Given this list of marker genes IFT140, PKD1, LRP5, ALG5, PKD2, PRKCSH, BICC1, ALG9, GANAB, DNAJB11, SEC63, here is a description of the gene set: Polycystic liver disease studied in species Homo sapiens Human Gene Set: HP_POLYCYSTIC_LIVER_DISEASE